Given this list of marker genes CEP57, COPB1, GABRD, REV3L, POLE, PTPN11, TMC8, ACP5, TNFRSF1A, NONO, ERCC6 (ERCC excision repair 6, chromatin remodeling factor), RTEL1, ESCO2, FANCI, GNAQ, WASF1, ATP2A2, SH3PXD2B, PRDM16, KRT5, MAX, SLC9A1, TNFRSF1B, KANSL1, IGF1, CYBA, MSH6 (NCBI Gene Id 2956), NHP2, ABCB6, ERCC5, NCF4, NCF2, DDB2, EP300, KCNAB2, SMARCAD1, SHOC2, SPRED1, MAPK1, PRKAR1A, NOP10, XPC, FANCB, HEPACAM, H4C5, TSC1, LUZP1, CIB1, CTC1, ADAM10, XRCC2, SMARCAL1, TP63, CTLA4, RAF1, ADAR, SASH1, STEAP3, BRCA2, SET, FANCF, CD28, ST3GAL5, COL17A1, GNAS, ERCC2, HMGA2, CBL, ERCC1, SPEN, TAF4, CWC27, GPNMB, PSENEN, CDKN1B, ATM, ERCC3, ANKLE2, HLA-B, PIK3CA, DSTYK, MLH1, TERT, FGFR3, LMNA, SOX10, GNB2, SVBP, CDKN1C, USF3, UBAP2L, MAP2K2 (mitogen-activated protein kinase kinase 2), UBE4B, GJB4, USB1, NF1, IL7, MMP23B, SDHC, IGF2, RAD51, FANCC, SLX4, PARN, RASA1 (RAS p21 protein activator 1), PORCN, CDKN2C, FANCL, IFNG, ARL6IP6, KIT (NCBI Gene Id 5086), TOMM7, DPP9, MSH2, ABCC9, SMARCA2, POGLUT1, SKIC3 (NCBI Gene Id 9652), PRKCD, CASZ1, ERCC4, DNAJC21, CSTA, CREBBP, COL3A1, ERCC8, RAD51C, APC, GJA1, KDM6B, INSR, C1R, ELOVL4, FANCM, UBR1, SNAI2, BUB1, RFWD3, KDM6A, BRAF, IRF1, CAPRIN1, RFX7, PDPN (podoplanin), IKZF1, PIGN, PCNT, TERC, ACTB, POFUT1, NPM1, MTOR, MEN1, CYBB, AKT1 (AKT serine/threonine kinase 1), TMC6, EPHB4, KRT14, IL6, PMS2, HLA-DRB1, KLLN, WRAP53, TMEM127, RBBP8, CLCN7, TWIST2, TGM5, PTEN, KITLG, CYBC1, PPP1CB, DKC1 (dyskerin pseudouridine synthase 1), MAP2K1, MAD2L2, ANAPC1, TRIP13, PLAG1, BRCA1, CDKN2B, BLM, TYMS, PLEC, XPA, BUB3, WBP11, DHX30, BRIP1 (BRCA1 interacting helicase 1), TINF2, UBE2T, PLXND1, NCF1, FANCD2, C1S, SKI, MAN1B1, STK11, ZMPSTE24, SPECC1L, TOP3A, ENPP1 (ectonucleotide pyrophosphatase/phosphodiesterase 1), TSC2, LZTR1, PHIP, RERE, PRKCZ, KRAS, SKIC2, SDHB, PDE11A, SLF2, HSPG2, NF2, KMT2D, MED12, VHL, GNA11, HLA-DQB1, BPTF, CHD8, GJB3, KDM5C, KDSR (3-ketodihydrosphingosine reductase), TP53RK, PALB2, RET, NBN, MMP2, SDHD, FANCG, SEC23B, CDKN1A, FANCA, DDX11, BUB1B, NRAS, FANCE, here is a description of the gene set: A flat, distinct, discolored area of skin less than 1 cm wide that does not involve any change in the thickness or texture of the skin. Human Gene Set: HP_MACULE species: Homo sapiens Macule